Given this list of marker genes Usp44, Rps7, Bag2, Rpl5, Rpl11 (ribosomal protein L11), Fbxo5, Cdkn2a, Mad2l2, Rpl23, Mad2l1, here is a description of the gene set: Mouse Gene Set: GOBP_NEGATIVE_REGULATION_OF_UBIQUITIN_PROTEIN_LIGASE_ACTIVITY Any process that stops, prevents or reduces the frequency, rate or extent of ubiquitin protein ligase activity. studied in species Mus musculus